Given this list of marker genes POLA1, PCNA, MCM3, POLD3, MCM4 (NCBI Gene Id 780917), MCM7, DNA2, GINS1, RFC3, POLE3, LIG3, LIG1, RFC4, POLD2, POLE, here is a description of the gene set: The process in which an existing DNA strand is extended by activities including the addition of nucleotides to the 3' end of the strand, complementary to an existing template, as part of DNA replication. Human Gene Set: GOBP_DNA_STRAND_ELONGATION_INVOLVED_IN_DNA_REPLICATION species: Homo sapiens